Given this list of marker genes Dlat, Pdha1, Pdhb, Pdk1, Pdk2, Dld, Pdhx, Pdha2, here is a description of the gene set: studied in species Mus musculus A multi-enzyme complex that catalyzes the oxidative decarboxylation of pyruvate to form acetyl-CoA. The complex comprises multiple copies of three enzymes referred to as E1, E2 and E3: pyruvate dehydrogenase (E1, which may be a homodimer or a heterotetramer of two alpha and two beta subunits, depending on species), dihydrolipoamide S-acetyltransferase (E2), and dihydrolipoamide dehydrogenase (E3). Additional proteins may also be present. Mouse Gene Set: GOCC_PYRUVATE_DEHYDROGENASE_COMPLEX